Given this list of marker genes KLHL29, SLC26A7, YPEL1, PIK3R1, SH2B1, SLC4A8, COL5A1, GREM1, EOLA1, TSC1, DYRK1A, ADGRG5, F2RL3, STMN4, ARK2N, CDK14, RNF222, CASZ1, TANGO6, PSME3IP1, TIFAB (NCBI Gene Id 497189), TAF8, SLC38A2, DCUN1D4, BACH2, PRKCA, INHBB, FIBCD1, KALRN, SNED1, MRAP, EVC, STX16, TESMIN, SLC10A3, ANO5, B4GALNT3, ZNF346, SH3KBP1, AMZ1, FBXL7, SLAIN2, GRAMD1B, DSC1, MTCL2, PTCH1, PPME1, LHX6, DMRT2, NCAPG, BSN, KCNA6, CD2AP, IL20RA, ANKH, QRICH1, TFAP4, TMEM178B, STKLD1, NKAIN2, JADE3, MEGF8, ARRB1, here is a description of the gene set: from publication Chen Y, Wang X (PMID 31504780) Genes predicted to be targets of miRBase v22 microRNA hsa-miR-4757-5p in miRDB v6.0 with MirTarget v4 prediction scores > 80 (high confidence targets). studied in species Homo sapiens Human Gene Set: MIR4757_5P